The following is a description of a gene set: Mouse Gene Set: GOCC_POST_MRNA_RELEASE_SPLICEOSOMAL_COMPLEX studied in species Mus musculus A spliceosomal complex that is formed following the release of the spliced product from the post-spliceosomal complex and contains the excised intron and three snRNPs, either U2 or U12, U5, and either U6 or U6atac., and this is the list of marker genes: Isy1, Cwf19l1, Gcfc2, Tfip11, Crnkl1, Ccdc12, Dhx15 (DEAH-box helicase 15), Xab2, Syf2, Cwf19l2, Yju2b